Given this list of marker genes IKZF4, PBX1, PCDH10, ATP6V1F, RHOT1, PCDHA7, NFATC3 (NCBI Gene Id 82543), PCDHAC2, PITPNC1, PTPRE, SYNGAP1, AGO1, WARS1, LRRC9, ZNF3, ARID1A, PCDHA9, PCDHA12, SLC30A3, CORO2B, SMG7 (SMG7 nonsense mediated mRNA decay factor), BSN, CAMK2D, FNDC3B, HCN4 (NCBI Gene Id 10021), TJP1, PCDHA8, SLC16A2, ST7L, SERF2, PAK5, KLK5, NFASC, HMGA2, ADGRB1, SNTA1, PCDHA4, KCNN3, CADM4, LUZP1, CARMIL3, ASB15, TMED5, MAGI1, PRX, DNAJB2, NTRK3, NR1D1 (NCBI Gene Id 9572), PCOTH, ATAT1, IGF2R, RAB14, SGMS1, PCDHA3, CDC42, PCDHA1, FMO2, HOXB5, BRCA1, KIF1B, LRFN5, PCDHA13, VEGFA, C2CD2L, PHYHIP, HIC2, PPP6R1, PHLDB1, ASTN2, LPCAT3 (lysophosphatidylcholine acyltransferase 3), SH3PXD2A, RAE1 (ribonucleic acid export 1), PAK6, DTX3, EFNB1, CPNE6 (NCBI Gene Id 9362), SF1, FAM53B, PCDHA10, ANXA2, RHOA, SOX13, TCF12, KIAA1328, MAT2A, NEUROD2, CA10, THRA, PRKAR2A, NPTN, MED13L, HSPA14, SSBP2, DCTN3, APBA1, SYNM, ADAMTS19, RIC8B, ATP1A3, APP, PCDHA11, EPHB2, PATZ1, RNF26, LRRC15, PCDHA2, MLLT11, PCDHAC1, PCDHA5, ADGRL1, PCDHA6, SLC37A2, FOXN3, GAP43, HIPK1, KDM2A, EMC10, MORN4, SNX19, RETREG3 (reticulophagy regulator family member 3), VEZF1, ZNF385A, PAX2, PHLPP2, here is a description of the gene set: studied in species Homo sapiens Human Gene Set: TCTCTCC_MIR185 Genes having at least one occurence of the motif TCTCTCC in their 3' untranslated region. The motif represents putative target (that is, seed match) of human mature miRNA hsa-miR-185 (v7.1 miRBase).